The following is a description of a gene set: from publication Cui A, Huang T, Li S, Ma A, Pérez JL, Sander C, Keskin DB, Wu CJ, Fraenkel E, Hacohen N (PMID 38057668) species: Mus musculus Cytokines mediate cell-cell communication in the immune system and represent important therapeutic targets. A myriad of studies have highlighted their central role in immune function, yet we lack a global view of the cellular responses of each immune cell type to each cytokine. To address this gap, the authors created the Immune Dictionary, a compendium of single-cell transcriptomic profiles of more than 17 immune cell types in response to each of 86 cytokines (>1,400 cytokine-cell type combinations) in mouse lymph nodes in vivo. A cytokine-centric view of the dictionary revealed that most cytokines induce highly cell-type-specific responses. For example, the inflammatory cytokine interleukin-1β induces distinct gene programmes in almost every cell type. A cell-type-centric view of the dictionary identified more than 66 cytokine-driven cellular polarization states across immune cell types, including previously uncharacterized states such as an interleukin-18-induced polyfunctional natural killer cell state. Mouse Gene Set: CUI_NEUTROPHIL_IL1B_RESPONSE_UP Genes positively differentially expressed in cell type: Neutrophil upon treatment with cytokine: IL-1β in mouse lymph nodes in vivo., and this is the list of marker genes: Rnasel, Cxcl3, Pnp, S100a9, Cxcr2, App, Rab44 (RAB44, member RAS oncogene family), Csf2rb, Xbp1, Wfdc21, S100a8, Lilrb4b, Lrg1, Il1r2, Retnlg, Srgn, Cd300lf, Cd177, Id1, Ier3, Cxcl2, Cish, Plaur, Cd14, Ccl6, Fcgr2b, Ltb4r1, Tarm1, Fth1, Ifitm6, Wfdc17, Lipg, Thbs1, Upp1, Basp1, Lcn2, Crispld2, Glipr2, Slfn4 (NCBI Gene Id 20558), Cd33, Ptpn1